Given this list of marker genes Ndufab1-ps, Mettl17, Malsu1, Oxa1l, Mrps27, C1qbp, Ndufab1 (NCBI Gene Id 72270), Uqcc5, Guf1, Tmem223, Taco1, here is a description of the gene set: Binding to a mitochondrial ribosome. Mouse Gene Set: GOMF_MITOCHONDRIAL_RIBOSOME_BINDING studied in species Mus musculus